The following is a description of a gene set: Human Gene Set: GOBP_LIPOXIN_METABOLIC_PROCESS The chemical reactions and pathways involving a lipoxin. A lipoxin is a non-classic eicosanoid and signaling molecule that has four conjugated double bonds and is derived from arachidonic acid. species: Homo sapiens, and this is the list of marker genes: ALOX15B, ALOX5, ALOX15, ALOX12, CYP4F3, PTGR1